Given this list of marker genes SESN1, CHM, PCMTD1, LANCL1, KIAA1217, DFFA, ZHX1, TNKS2, GALR1, ONECUT2, HERPUD1, TTC8, SEC24A, PPP2R1B, BLCAP, EMILIN2, TANC2, ZBTB41, ENPEP, PRTG, EPN2, MED14OS, WNK3 (WNK lysine deficient protein kinase 3), ID4, ACTL6A, WDTC1, RETREG1, ARPP19, ATP11A (NCBI Gene Id 84170), PIK3CA, PPA1, CXCL14, OTUD7B, CXXC4, RREB1, ADIPOR1, FOXG1, STRN3, PELI2, FBXO28, SOX4, ZNF281, ICMT, CUX1, TBC1D15 (TBC1 domain family member 15), ITSN2, CYLD, PTPRB, OPRM1, NEXMIF, FZD3, MYH10, MZT1, ZC3H11A, CRYBG1, ELOVL6, CPD (NCBI Gene Id 1362), CEP170B, SATB2 (SATB homeobox 2), MSANTD4, ZBTB33, INSM1, VGLL3, STK24, E2F7, RAP2A (RAP2A, member of RAS oncogene family), CBFA2T3, PHF3, GJB2, THUMPD3, FBXO42, MTSS1 (MTSS I-BAR domain containing 1), GPR17, ZNF615, CPNE8, KLLN, ATP7A, QTRT2, ONECUT1, CSDE1, GOT2, HSPA4, IGF1, ANLN, NAA20, LPGAT1, SH3BGRL, PLEKHA5, AHCYL1, CDH2, DCLK1, ENY2, ZC3H7B, RYR3, SLITRK6 (NCBI Gene Id 84189), MYRF, MBTPS2, ITGB1, FAM135B, RBBP6, POLK, DYNC2H1, OSBPL3, CEMIP2, DMD, PCDH7, GABRA1, ST3GAL1, ABCC5, ETFA, FPGT, STAG2, GRID2, PHIP, KLHL15, TPD52, YAF2, PLCG1, PDE4D, TGFB2, MICAL2, UXS1 (UDP-glucuronate decarboxylase 1), RAI2, NTAQ1, POU3F2, RBBP5, ZNF90, CCNA2, PTPN13, SMARCE1, RASSF8, PAN3, STC1, FBXO33, MTDH, FAM91A1, PDK1, RPS6KA2, PKHD1L1 (NCBI Gene Id 93035), SIX6, ZDHHC21, RNF168, HIC2, ZFHX3, LEPR, DCBLD2, MYO10, NSUN2, HSPH1, SLC12A2, CSNK1G3, STX6, GPBP1, COX7A2L, NDUFA10, TRIM36, CEP68, ACBD3, NRXN1, CASZ1, PLXDC2, QSOX2, KAT2B, TESMIN, STIM2, ZNF704, TPD52L2, NAA15, AUTS2, LARS1, AGFG1, RRP1B, CLASP2, MINAR1 (membrane integral NOTCH2 associated receptor 1), SLC17A5, ACVR2B, ZNF664 (NCBI Gene Id 7729), FIGN, CPEB3, TMEM64, MBLAC2, BHLHE22, LHFPL3, MFSD14A, KITLG, SPOPL, C21orf91, CCDC198, TGFBR2, CDH1, WDR1, ZFHX4, ACSL4, PPM1A, KIAA0408, TRABD2B, SREK1IP1, ARFIP1, SLC15A2, TSC22D4, ZNF99, KCTD9 (potassium channel tetramerization domain containing 9), CERT1, TIAM1, ESM1, SOCS4, RAB14, ZNF512, SCAI, DAZAP1, DCP1A, FBXO11, REST (RE1 silencing transcription factor), SFMBT1, MORC4, CDKN1C, DMP1, SMARCC1, ARL5A, DENND4A, ZBTB11, ERMN, WWTR1, RNF138, TENT4B, CAPZA1, POU2F1, CEP41, IFT80, ASPH, DR1, DCUN1D4, ZNF292, RELT, VKORC1L1, STRIP2, ANO5, CNOT6, YOD1, CCSER2, AP3M1, CEACAM6, MAP3K1, RBPJ, SYNE2, ARL4A, UBR3, NXT2, ARID2, COPS2, PRKAA2, TCEA1, CGGBP1, BNIP3L, BICD2, BOD1L1, CASP7, JAZF1, CCND2, FOXC1, VASH2, ZBTB44, PDCD4, HIPK3 (homeodomain interacting protein kinase 3), ARHGAP5, HYCC2, SPRED1, USP46, PURB, MTMR12, TMEM167B, GNS, ELL2, CLCN4 (chloride voltage-gated channel 4), TNPO1, CYYR1, CREB5, KCNS3, CCDC121, VDAC1, TMEM255A, GNPDA2, LSM8, ANKFY1, TLE4 (NCBI Gene Id 7091), ACOT7, DNAJA1, LPIN3, RELL1, ADCY3, E2F1, CFL2, RIT1, GPR19, RAPGEFL1 (NCBI Gene Id 51195), ZCCHC2, CNTNAP5, HIPK2 (NCBI Gene Id 653052), MEX3D, RNF217, CNTN1, LMO3, MDK, PHTF2, PIK3R1, SAV1, TMEM266, CPA3, IGF2BP3, ECPAS, GABPB2, MPPED2, KRT12, NUFIP2, ZWILCH, DLG2, SLC10A7, PHC1, MXI1, MAGI1, LRRTM1, NQO2, CSGALNACT2, YIPF5, C5orf24, LRRC4, LRP6, TRIM32, APP, YTHDF1, ZSWIM6, ZNF148, SESTD1, PRKAR1A, SESN3, TFAP2B, SLC36A4, HAPLN1, FSD1L, PPP1R12B, SHMT1, here is a description of the gene set: Human Gene Set: MIR9_3P studied in species Homo sapiens from publication Chen Y, Wang X (PMID 31504780) Genes predicted to be targets of miRBase v22 microRNA hsa-miR-9-3p in miRDB v6.0 with MirTarget v4 prediction scores > 80 (high confidence targets).